The following is a description of a gene set: species: Mus musculus Mouse Gene Set: MIR_29A_3P from publication Chen Y, Wang X (PMID 31504780) Genes predicted to be targets of miRBase v22 microRNA mmu_miR_29a_3p in miRDB v6.0 with MirTarget v4 prediction scores > 80 (high confidence targets)., and this is the list of marker genes: Col2a1, Erc1, Tet1, Nfat5, Mxd1, Crispld1, Adamts6, Slc5a8, Aco1, Ythdf1, Adamts2, Adam19 (ADAM metallopeptidase domain 19), Kcnip2, Col7a1, Col4a3, Slc4a7 (NCBI Gene Id 218756), Jarid2, Has3, Pcdha7, Wdcp, Rere, Kmt5a (lysine methyltransferase 5A), Map6, Naa40 (N(alpha)-acetyltransferase 40, NatD catalytic subunit), Adamts10, Senp1, Atrn, Nsd1, Arvcf, Stard8, Bmt2, Pcgf3, Pcdha6, Gng12, Rapgefl1, Robo1, Sh3pxd2a, Vash1 (vasohibin 1), Vegfa, Fubp1, Blm, Sparc, Samd4, Dbt, Tet2, Pdik1l, Sypl2, Tarbp1, Unc13b, Efna5, Cldn1, Pik3r1, Dcun1d4, Zbtb10, Ccnl2, Traf3, Sestd1, Cpsf7, Brwd3, Palm, Fam168b, Taf5, Sppl2b, Rev3l, Ric1, Lox, Mycn, Matn3, Zbtb34, Akap5, Ddx3x, Tet3, Tfec, Asxl3, Ky, Npas3, Zfp36l1, Pcdhac2, Lin7a, Eif4e2, Klhl28, D630045J12Rik, Zfp568, Dcx, Eva1b, Sms, Tfeb, Tspan4, Mtmr4, Pcdha8, Kdm2a, Hecw1, Rab30, Ythdf3, Wwtr1, Eps15, Pcdha2, Tll1, Morf4l2, Rmnd5a, Kdm5b, Usp37, Tlcd3b, Nckap5, Wdfy1, Pcdha12, Col9a1, Fer, C1qtnf6, Dynlt1b, Or2ag2b, Ccnyl1, Smim17, Slc25a3, Enho, Mapkbp1, Col6a3, Ccdc28b, Col4a5, Col25a1, Adamts18, Rnf19a, Fam167a, Zfp512b, Tpm1, Ireb2, Entpd7, Fbn1, Nup160, Trafd1, Amer1, Nap1l3, Zfp282, Nkapd1, Mark3, Pmp22, Pcdha9, Jazf1, Pcdha1, Atp2b4 (ATPase, Ca++ transporting, plasma membrane 4), N4bp2l1, Dtwd2, Taf7, Nkiras2, Gxylt2, Hrk, Mfap5, Tnfrsf1a, Ubn1, Narf, Adamts17 (NCBI Gene Id 767813, ADAM metallopeptidase with thrombospondin type 1 motif 17), Col5a3, Col5a1, Pten, Ak3, Mybl2, Pcsk5, Pcdhac1, Kcna5, Wbp1l, Plp1, Proser1, Zdhhc21, Lif, Lpl, Erlin2, Nasp, Rest, Abce1, Tcf4, Ppm1d, Rarb, Zbtb5, Mfap3, Zfp36, Col5a2, Ppp1r1c, Kmt5c, Glis2, Gpr161, Frat2, Fbxw9, Sidt1, Shroom2, Fam241a, Serpina1f, Eml5, Elovl4, Col22a1, Slc43a2, Arrdc3, Fermt2, Fstl1, Gid8, Bach2, Slk (STE20-like kinase), Rab6b, Mcl1, Uaca, Eln, Rnpepl1, Camk4, Gtpbp2, Col4a2, Stx16, Xkr7, Smurf2, Adipor1, Klf4, Eml4, Dpp3, Dnmt3b (NCBI Gene Id 13436), Purg, Ldlrap1, Gpr37, Hmcn1, Kif26b, Fem1b, Foxj2, Ppic, Serpinh1, Dpysl2, Clock, Col8a1, Hapstr1 (HUWE1 associated protein modifying stress responses), Abcb6, Adam12, 0610030E20Rik, Dusp2, Hdac4, Ankrd13b, Nktr, Dio2, Gpcpd1, Akt3, Bltp3b, Cd276, Nrep, Dennd1b, Adamts9, Tubb2a, Pcdha4, Fras1, Col4a6, Sp1, Stmn2, Slc30a3, Col19a1, Syn3, Tmem183a, Otub2 (NCBI Gene Id 72396), Map4k4, Arf2, Zfp704, Calcr, Tmem169, Hormad1, Pcdha5, Igsf9b, Col11a1, Pxdn, Kif26a, Dicer1, Hcn1, Morf4l1, Trim63, Pgap1, Dlg2, Pdgfa, Ppp1r3d, Iffo1, Col15a1, Col4a1 (collagen, type IV, alpha 1), Atad2b, Bmf, Rnd3, Tnrc18, Slc19a3, Igf1, Hspg2 (NCBI Gene Id 15530), Rexo1, Chfr, Nav1, Fbxw7, Ifi30, Otud4, Dnmt3a, Psma3, Bak1, Adamts16, Mbtd1, Zbtb47 (NCBI Gene Id 97572), Zmiz1, Zfx, Etv4, Smpd3, Elf2, Apc, Edaradd, Ccser2, Icos, Csrnp2, Dgkh (NCBI Gene Id 380921), Sgk1, Slc31a1, Zfp91, Traf4, Il1rap, Gpx7, Natd1, Atp1b4, Sh3bp5l, Chsy1, Nfia, Pi15, Tmtc3, Zfp346, Adamts7, Ptbp3, Eomes, Iqschfp, Cdk6, Kdm4b, Ttc9, Gpr82, Mtfr2, Arpp19, Amot, Ppm1e, Trib2, Pgap2, Lysmd1, Mex3b, Grip1, Hbp1, Pan2, Pcdha11, Prkra, Timd2, Dpysl5, Smtnl2, Pcdha3, Dgkd, Rfx7, Col27a1, Carmil1, Nav2, Col1a1, Eml6, Zmym2, Ybx3, Fscn1, Col3a1, Nexmif, Tpk1, Pcdha10